The following is a description of a gene set: Catalysis of the reaction: GDP + H2O = GMP + phosphate. species: Homo sapiens Human Gene Set: GOMF_GDP_PHOSPHATASE_ACTIVITY, and this is the list of marker genes: ENTPD7, ENTPD5, ENTPD1, CANT1, GBP1, ENTPD4, ENTPD2, ENTPD3, ENTPD6, ENTPD8